The following is a description of a gene set: electronically inferred by orthology from the curated human pathway This event has been computationally inferred from an event that has been demonstrated in another species.<p>The inference is based on the homology mapping from PANTHER. Briefly, reactions for which all involved PhysicalEntities (in input, output and catalyst) have a mapped orthologue/paralogue (for complexes at least 75% of components must have a mapping) are inferred to the other species. part of: Activation of GABAB receptors studied in species Mus musculus Reactome Pathway: Inhibition  of voltage gated Ca2+ channels via Gbeta/gamma subunits, and this is the list of marker genes: Kcnj12, Kcnj5, Gng3, Gnb2, Kcnj3, Gngt1, Gnb3, Gnb5, Gabbr1, Gng8 (guanine nucleotide binding protein (G protein), gamma 8), Gng10 (NCBI Gene Id 14700), Gngt2, Gng4 (guanine nucleotide binding protein (G protein), gamma 4), Gng11, Kcnj10, Kcnj2, Gng7, Gng5